The following is a description of a gene set: Genes predicted to be targets of miRBase v22 microRNA mmu_miR_5618_5p in miRDB v6.0 with MirTarget v4 prediction scores > 80 (high confidence targets). species: Mus musculus from publication Chen Y, Wang X (PMID 31504780) Mouse Gene Set: MIR_5618_5P, and this is the list of marker genes: Ubn2, Alx1, Pde7a, Nova1 (NCBI Gene Id 664883), Ncam2, Spty2d1, Nlrp4b, Sh2b1, Acvr2a, Onecut2 (NCBI Gene Id 328974), Mrpl40, Yes1, Cubn, Golt1b, Relt, Mthfd2, Cyp2j5, Kcnd3 (potassium voltage-gated channel, Shal-related family, member 3), Zfp516, Rai2 (NCBI Gene Id 24004), Tardbp, Dusp6, Slc9a6, Uhmk1, Srsf3, Nucks1, C330018D20Rik, Arhgef39, Lrrn3, Usp27x, Erbin, Gnaq, Ppp6c, Tspan2, Esco1 (NCBI Gene Id 77805), Abcc2, Add1, Gramd1a, Syncrip, Hp1bp3, Mgat4b, Sox9, Macroh2a2, Igsf5, Setbp1, Cnot6, Rcn2, Insig1, Anln, Phf6, Sox5, Ip6k1, Oaz3, Gata6, Fsd1l, Cab39, Szrd1, Shq1 (NCBI Gene Id 72171), Alox5ap, Rasal3, Pigg, Gmfb, Ano4, Cetn2, Tac2, Adam23, Samd4, Tbx15, Cfl2 (cofilin 2, muscle), Pax6